Given this list of marker genes Asah1, Spr, Gba1, Sgpp2, Sptlc3, Pcbd1, Gch1, Acer2, Plpp3, Naaa, Abca2, Sphk2, Sgpp1, Sptssb, Sptssa, Acer3, Plpp2, Asah2, Sptlc1, Qdpr, Pcbd2, Sphk1, Plpp1, Degs2, Acer1, Ephx1, Pts, Agk, Lrp2, Dhfr, Sptlc2, here is a description of the gene set: Mouse Gene Set: GOBP_DIOL_METABOLIC_PROCESS species: Mus musculus The chemical reactions and pathways involving a diol, a compound that contains two hydroxy groups, generally assumed to be, but not necessarily, alcoholic.